The following is a description of a gene set: from publication Ng SY, Yoshida T, Zhang J, Georgopoulos K (PMID 19345118) species: Homo sapiens Human Gene Set: GSE15330_HSC_VS_GRANULOCYTE_MONOCYTE_PROGENITOR_DN Genes down-regulated in hematopoietic stem cells versus granulo-monocyte progenitors. Regulation of lineage potential and transcriptional priming by Ikaros. New insight is provided into a bivalent regulation of lineage priming in the HSC and its lympho-myeloid restricted progeny the LMPP by the lymphoid lineage-determining factor Ikaros Whereas Ikaros is responsible for the activation of a cascade of lymphoid expression programs and for the establishment of lymphoid potential from the HSC to the LMPP it is also responsible for the repression of stem cell and erythroid genetic programs that are incompatible with further lineage restrictions emanating from the LMPP, and this is the list of marker genes: RAB2B, FHDC1, TBC1D13, APP, ARMC10, NEAT1, SNX18, SHPRH, MED14, PEX5, HACD3, IDUA, PSME2, IER5, ZBTB7A, HIF1A, AEN (apoptosis enhancing nuclease), PPP1R14B, BET1L, TESK1, IL21R, SERTAD1, NUDT3, GLYR1, ANKIB1, IREB2, SLFN12L, AP1G1, DPH2, NDUFAF4, FAM220A (NCBI Gene Id 84792), COMMD4, ATXN7L3, STEAP1, IL2RG, GATA5, SOD3, NEUROG3, NDEL1, WARS1, TMA16, UBE2W, AMPD2, EMC6, FAM162A, CERS2, CTSV, SIMC1, KLF15, TMEM68 (transmembrane protein 68), SIAH1, TSPAN5, DMAP1, SELENOS, USP24, TAB3, BCCIP (NCBI Gene Id 56647), ERI3, PRR3, IRF3, WDR45B, DAZAP2, INTS12, UBP1, PAFAH1B1, C8orf82, BLTP3B, NEMF, PSME1, NEFH, POLR2F, PTPRC, CXXC1, METAP1, CCL22, RRAD, APBA3, KLRK1, NFKBIL1, LDAH, ATP6V1B2, TACC2 (transforming acidic coiled-coil containing protein 2), ADPGK, RGS20, ALAS2, KGD4, AASS, RARS1, PRSS8, TNFRSF1B, MEF2A, FOXJ2, TBC1D23, ATP6V0B, SLC12A2, ATG5 (autophagy related 5), GABARAP, PLEKHA5, UBE2G1 (ubiquitin conjugating enzyme E2 G1), ZBTB22 (zinc finger and BTB domain containing 22), TNKS2, LATS2, MAFB, SNRK, SEM1, FIBIN, SCAF8, ESD, LSM14B, MED1, NSFL1C, SAFB, PRKCI (protein kinase C iota), MAPK11, LCMT2, ASCL2, SPON2, SDF2, TRAPPC14, SNRNP48, PSCA, HAND1, UTP4, UBE2F, ARHGAP17, COA5, LAT2, KRT27, GET3, TAB2, GATAD2B, ZNF296, ASCC2, HIVEP3, CCND2, SPPL3, PDCD5 (programmed cell death 5), PWP2, GSTT2, MESD (NCBI Gene Id 23184), PPP1R3C, CDC37L1, LAT, NCKAP1, ARF6, C3orf62, PER1, G6PC1, ALCAM, POLR3G, DUSP7, SDF4, CREB3L2, NFAM1, LSG1, NEK9, CRK, SYT1, ACOT8, C2orf76, SELENOT, SLC5A3, ZWINT, RPS15A, POLR3A, CYBC1, SEC23IP, SAC3D1, RDH14, ITGA3, PEX11A, HBB (NCBI Gene Id 3043), NDUFA6, RCAN1, FAIM, SLC26A4, HSPB7, THAP12, GPS2, RFFL, AP3S2 (NCBI Gene Id 8885), KLHL21, UQCC2, WDR83OS, FBXW11, POU2F2, OGT, NDRG1, RPP40, LEMD2 (NCBI Gene Id 221496), NR2C2AP, EMC3, GABPA, POLR1B, SAP30L, SCRN3, POLR3F, CD40, HECTD1, RNF130